The following is a description of a gene set: The chemical reactions and pathways resulting in the breakdown of glycosaminoglycans, any one of a group of linear polysaccharides composed of repeating disaccharide units. species: Homo sapiens Human Gene Set: GOBP_GLYCOSAMINOGLYCAN_CATABOLIC_PROCESS, and this is the list of marker genes: TGFB1, SPAM1, SGSH, HMMR, CEMIP2, STAB2, PGLYRP4, PGLYRP2, LYG1, FGF2, HYAL2, CD44, LYG2 (NCBI Gene Id 254773), IDUA, PGLYRP3, HYAL1, HYAL3, PGLYRP1, HEXB, CEMIP, HYAL4, HEXA, GUSB, LYVE1 (lymphatic vessel endothelial hyaluronan receptor 1), GNS (NCBI Gene Id 2799), IDS